Given this list of marker genes TIMMDC1 (NCBI Gene Id 51300), MECP2, TRAPPC12, COX8A, NDUFB11, NDUFA10 (NCBI Gene Id 4705), COX6B1, MT-CO1, MDH2, NDUFA11, MT-ND1 (mitochondrially encoded NADH:ubiquinone oxidoreductase core subunit 1), GLRX5, UQCC2, NDUFAF5, COX11, NDUFB8, MT-ND6, SCO2, RRM2B, MT-TS2, NDUFAF4, ALDH4A1, DNM1L, NUBPL, HMBS (NCBI Gene Id 5448), MT-ND3 (mitochondrially encoded NADH:ubiquinone oxidoreductase core subunit 3), UQCC3, NDUFB9, RMND1, TPK1, GFM2, SLC31A1, COX14, TIMM50, MT-ND2, MT-TN, NDUFV1, NDUFAF8, NDUFA1, LYRM7 (LYR motif containing 7), HTRA2, NDUFS7 (NCBI Gene Id 4727), LONP1, COX10, PNPT1, SLC13A3, MPV17, SUCLG1, NDUFS3, TXN2, ATP5PO, NDUFAF2, MRPS34, PDHA1, MT-TL1, TRMT10C (tRNA methyltransferase 10C, mitochondrial RNase P subunit), NDUFA6, COX4I1, AIFM1, DARS2, PET117 (NCBI Gene Id 100303755), NDUFV2, NDUFS6, OPA1, NDUFAF3, PET100, MT-ND4 (mitochondrially encoded NADH:ubiquinone oxidoreductase core subunit 4), MTFMT, NAXE, GFM1 (NCBI Gene Id 85476), IBA57, NARS2, HSD17B10, NDUFA8, MT-TV, COX20, NDUFA12, NDUFAF1, SLC25A19, NDUFA4, SURF1, ATPAF2, SLC39A8, NADK2, MT-TK, MT-TH, NDUFB3, MT-CO2, NDUFB10, CLPB, SLC25A4, HPDL, ECHS1, FOXRED1, FARS2, RARS2, LYRM4, MT-ATP6, PDHX, COA8, MT-CO3, NFU1, MT-TW, NDUFS1, NDUFS4, NDUFS2, LRPPRC, MT-TF, NDUFS8, SUCLA2, MT-ND5, SLC2A1, COQ8A, MT-TQ, TMEM126B (NCBI Gene Id 95018), here is a description of the gene set: Abnormal concentration of lactate in the cerebrospinal fluid. Human Gene Set: HP_ABNORMAL_CSF_LACTATE_CONCENTRATION Abnormal CSF lactate concentration species: Homo sapiens